Given this list of marker genes PTPRC, LEF1, CARD16, SOCS4, RBCK1, NWD1, WAPL, TCEAL7, SERPINB13, TFAP4, MAPK8, PPM1E, SERPINB8, ERRFI1, CEBPG, PARP9, CYLD, ROCK1, SMO, ECM1, BTAF1, DNAJA1, TNKS, DBNDD2, MIR92B, ARRB2, TNNI3, CR1, PTPRJ, IFIT2, TRAF3, BAX, THY1, PSEN1, COMMD6, DAB2IP, OSR1, PXK, SPOCK2, EDNRB, IFI16, NPPA, CDKN1A, LRRC14, PBX1, DACT1, GSKIP, CRB2, TMIGD3, BCL3, PEX14, PHB2, AIM2, EIF4A2, FOXP3, ERBIN, ADGRG3, MIDN, BANF1, DDX11, PAXIP1, PIAS2, STK38, IL10, ACOD1, CDKN1C, LATS2, NDFIP2, AURKA, PSMD10, SUMO3, TAF7 (TATA-box binding protein associated factor 7), ADIPOQ, ZGPAT, APC, STK39, PTPN1, GNAI2, GNL3L, GPR35, TRIM21, PEX19, PRKN, PLXNB3, SERPINA5, MIR148A, NLRP2B, ZNF431, MAD2L1, CEACAM1, ADGRV1, SLPI, CFHR5, ZFYVE28, DEFB114, MIR27B, CACTIN, USP7, PAQR3, TARBP2, TFDP3, UBLCP1, CDK5RAP1, MIR138-1, DRD5, SPOCK3, NFKBIA, ADORA3, KCNE2, CRHBP, NDFIP1, CTTNBP2NL, RRP1B, PSME3IP1, MYCNOS, ZFP36, PYDC1, SERPINB4, FBXO5, ID1, SIK1, KCNE1, LRRK2, UBXN1, GATA1, DEPTOR, LTF, EPM2A, HNRNPU, YWHAG, NLRC3, SUMO4, COMMD7, CFHR2, ILRUN, CHP1, MAP3K10, LTB4R2, STYX, LATS1, CAMK2A, HMGA2, SERPINB9, TLR9 (NCBI Gene Id 54106), GSK3A, NES, GEMIN2, NPRL2, CAMK1, XRCC1, GNAI3, NEIL1, URI1, AGT, POU4F2, PTPN22, PRMT2, TRIM37, CCAR2, RECK, GZMA, CORO1C, SETD6, MT3, TNNT2, SERPINB3, GABBR2, RTRAF, NFIB, NPM1, TIMP1, KLRC4-KLRK1, GADD45A, ARL2, CTNNBIP1, PRDX3, CALM2, TMC8, CHMP6, NT5DC2, TSG101, GAPDH, GFI1, TMBIM1, PARP10, GPSM1, JUN, PIM1 (NCBI Gene Id 82453), NLRC5, ID3, CLEC12B, PIN1, EPPIN, DFFA, RAMP3, NFKBIL1, GPRC5A, PYDC2, FMR1, KCNRG, RPL11, ITGA4, ITGB1BP1, AIDA, RSF1, NOTCH1, SOCS5, GRP, INCA1 (inhibitor of CDK, cyclin A1 interacting protein 1), TRIM40, UBQLN1, MITD1, CBARP, LYN, KCNQ1, KCNAB1, CALM1, PAK2 (p21 (RAC1) activated kinase 2), ADARB1, SUMO1, APOE, RGS14, CCR2, RACK1, ADAR, CDKN2A, VCPKMT, KLRK1, ABL1, RPL5, FICD (NCBI Gene Id 11153), PTK6, MAPK8IP1 (NCBI Gene Id 9479), DTX3L (deltex E3 ubiquitin ligase 3L), CAND1, GOLGA2, CACNA1F (NCBI Gene Id 778), CD300A, KCNE3, PKIA, SIRT1, LRPAP1, HEYL, ADAM15 (NCBI Gene Id 8751), TIMP2, PPIF, DUSP7, ACP4, GOPC, AKAP5, HIPK3, TMED2, GCKR, FETUB (NCBI Gene Id 56684), RIPOR1, RD3, SERPINB1, CRHR1, RNF2 (ring finger protein 2), MAD2L2, FOXS1, DUSP1, OTULIN, MEN1, IFIT1, SLN, CPNE1, ANK3, SH3BP4, TP53 (tumor protein p53), PPP1R12A, CDKN1B, RIPOR2, MVP, UFL1, RWDD3, TSC1, EFHB, MTURN, PTPRF, ZNF593, APBA3, RB1, GNB5, PLIN5, STMN1, PRDX5, AKT1S1, TRIM27, BRMS1, GTF2F1, OXA1L, ESR1, USP44, MDFI, CHUK, PYCARD, CDK5RAP3, HEY2, CFHR1 (NCBI Gene Id 82407), NUPR1, GLA, SYMPK, CALM3, PRKCH, RCC2, PKHD1, RPS7, ABCE1, ID2, VPS25, CNRIP1 (cannabinoid receptor interacting protein 1), COMMD1, RPL23, MMP9 (NCBI Gene Id 4318), GNAT1, ARFGEF1, XIRP1, CARD18, USP17L2, MET, LRCH1, MACROH2A1, CEP85, PLN (NCBI Gene Id 5350), E2F1, CYP1B1, PDCD4, CSNK1E, ATP5IF1, RASIP1, NOSIP, FLNA, SRCIN1 (SRC kinase signaling inhibitor 1), NR0B2, RDX (radixin), PPIA, WARS1, RASA4, USP33, GSK3B, ARRB1, DNAJB2, SOX11, WWP2, TCAF2, PAM16, CEP43, GRM2, SNX6, HAVCR2, SFN, GALR1, TLE5, CMKLR1, RALB, HEG1, GRM3, EIF2AK4, here is a description of the gene set: Human Gene Set: GOBP_NEGATIVE_REGULATION_OF_MOLECULAR_FUNCTION studied in species Homo sapiens Any process that stops or reduces the rate or extent of a molecular function, an elemental biological activity occurring at the molecular level, such as catalysis or binding.